Given this list of marker genes Eif2a, Cpeb2, Eif3l, Dhx29, Eef1d, Eif5b, Tsfm, Eif4e, Mtif3, Eif1ad, Eif2b5, Eif2b3, Eif1ad13, Abtb1, Eif1ad3, Eif3e, Eif1, Eif1ad17, Eif3f, Eif4g2, Eif4a2, Efl1, Cpeb3, Eif3j1, Eif1b, Eif1ad14, Mtif2, Eef2k, Eif1ad8, Eif3h, Eif2b4, Eif2b2, Eif3d, Eif3b, Eif2s2, Eif1ad19, Eif4e1b, Neurl1a, Eif6, Eif4g3, Etf1, Denr, Eif1ad15, Eefsec, Eif1a, Eef1g, Eif2s3x, Eif3a, Eif4g1, Gspt2, Eef1a2, Eif3k, Eif5a, Eif2s3y, Tufm, Eef1b2, Eif1ad16, Eif3m, Eif2d, Eif1ad2, Eif1ad7, Cpeb1, Gfm1, Eef2, Eif5a2 (NCBI Gene Id 83812), Gtpbp2, Cpeb4, Eif2s1, Mtrf1l, Eif3g, Gtpbp1 (NCBI Gene Id 97981), Eif3c, Mtrf1, Eif3i, Mrpl58, Eif1ad11, Eif1ad18, Eif4a1, Eif3j2, Mtrfr, Eif4b, Eif4h, Eif1ad4, Eif2b1, Eif5 (eukaryotic translation initiation factor 5), Eif4e2, Mcts1, Gspt1, Eef1a1, Eif4e3, Eif1ax, Hbs1l, Eif1ad12, here is a description of the gene set: studied in species Mus musculus Mouse Gene Set: GOMF_TRANSLATION_FACTOR_ACTIVITY A molecular function required for translation of a mRNA into a protein functioning as part of initiation, elongation or termination of translation.